The following is a description of a gene set: electronically inferred by orthology from the curated human pathway This event has been computationally inferred from an event that has been demonstrated in another species.<p>The inference is based on the homology mapping from PANTHER. Briefly, reactions for which all involved PhysicalEntities (in input, output and catalyst) have a mapped orthologue/paralogue (for complexes at least 75% of components must have a mapping) are inferred to the other species. studied in species Mus musculus part of: Mitochondrial Fatty Acid Beta-Oxidation Reactome Pathway: mitochondrial fatty acid beta-oxidation of unsaturated fatty acids, and this is the list of marker genes: Eci1, Decr1